The following is a description of a gene set: species: Homo sapiens Human Gene Set: GOBP_REGULATION_OF_DEVELOPMENTAL_GROWTH Any process that modulates the frequency, rate or extent of developmental growth., and this is the list of marker genes: FOXS1, RAB21, EDN1, FOXP1 (NCBI Gene Id 87246), KCNK2, RUNX1, ITSN2, GHRH, TP73, RTN4R, PPIB, YY1, NACA, CDKL3, SYT17, ARX, GATA6, STK3, AKT1, SMAD7, CDK1, GDI1 (NCBI Gene Id 2664), ADRB3, ATG16L1, TTL, MIR548C, GPAM, TBX2 (NCBI Gene Id 6909), MKKS, MIR200B, BCL2, NIPBL, EZR, SYT2, CLASP2, ZMPSTE24, GPAT4, SHTN1, SLIT1, NRCAM, APP, YAP1, FTO, TRPC5, ADCY10, COLQ, GPR21, SEMA7A, MIR19A, MIR1-1, PLAC8 (placenta associated 8), PLAA, HMGA2, CXCL12, SLC6A4 (solute carrier family 6 member 4), SERP1, GHRHR, RIMS1, NKX2-5, FN1, CTTN, STC2, CGA, VEGFA, PARP2 (poly(ADP-ribose) polymerase 2), SEMA3G, CREB1, NPY1R, LATS2, SOCS2, CDKN1B, RTN4, GHR, PIK3CA, ADRB2, ADNP, RNF6, EPPK1, SEMA3A, MAPK11, STK4, AFG3L2, FGF20, TBX5, PAFAH1B1, RIMS2, DCC, ADRB1, FOXC1, WNT5A, JARID2, IGF1, GHRL (ghrelin and obestatin prepropeptide), MFSD2A (MFSD2 lysolipid transporter A, lysophospholipid), NOG, MAP2, TGFBR1, SOX15, PLXNA4, GH1, SIX4, LGMN, MIR204, WWC2, POU3F2, RAG2 (NCBI Gene Id 5897), CACNA2D2, PTPRS, MIR17HG, CACNG7, ULK2, SPAAR, ISLR2, ZFPM2, ANAPC2, SEMA3F, ABL1, LIMK1, AR, NRG1, FXN, SGPL1, FGFR3, GLI1, CPNE5, HDAC3, MYOD1, SEMA6C, MIR509-1, DIO3, GDF15, FGFR2, LIN7A, DIP2B, BMP10, SIN3A, SIX1, CPNE6, AGR2, ACTN3, DRAXIN, MT3, SPART, CRABP2, DRD2, NEDD4L, AKAP6, PPARA, NGF, DNM2, HOPX, PEX5, SPP1, NOTCH1, ARHGAP4, SEMA6D, MIR590, KIAA0319, MAPT, RGS4, SLC6A3, PLXNA3, COL14A1, LATS1, BARHL2, RUFY3, RNF157, WWC3 (NCBI Gene Id 55841), DLL1, MIR208A, UNC13A, MUSK, MEF2C, CTDP1, WNT3, INSR, SEMA4D, SYT4, FOSL2, TRIM46, MIR873, IFRD1, CAV3, MIR199A1, APOE, CAPN3, MEGF8, MIR29B1, LPAR3, FGF13, STAT5A (signal transducer and activator of transcription 5A), NTN1, MIR19B1, BASP1, G6PD, ULK1, MIR222, RBPJ, GJD4, MSTN, RYK, MAG, EPHA7, TGFBR3, TNR, ZP3, HSF1, SMO, OLFM1, FGF8, TNFRSF12A, SOD1, HDAC6, LIN7C, HTRA2 (NCBI Gene Id 27429), PLS1, BMPR2, SYT3, MYOZ1, EFNA5, SAV1, RBP4, PTCH1, ACACB, CDKN1A, CDKL5, RGS2 (regulator of G protein signaling 2), DUSP6 (NCBI Gene Id 1848), ATRN, VGLL4, PPARD, NPPC, WNT2, LIN7B (NCBI Gene Id 64130), BDNF, LEP, CPNE9, MYCBP2, IL7, MAPK14 (NCBI Gene Id 1432), RND2, GOLGA4, NTRK3, RGMA, POU4F2, OSTN, GAMT, ERBB4, AGRN, GRN, STAT3, DSCAM, PIM1, TOMM70, PAK1, SEMA4F, ZFYVE27, MTM1, IGF2, HEY2 (hes related family bHLH transcription factor with YRPW motif 2), NRP1 (NCBI Gene Id 8829), GDF5, RAI1, GHSR, SLC23A2, BBS4, FOXC2, BCL2L11, MAP3K13, NKX6-1, GNAS, IST1, CFL1, VIL1, DUSP10, RASAL1, PTEN, GSK3A, SMURF1, TWF2, PI16, WWC1, MIR25, TLL2, SPTBN4, PROX1, MYH6, HNF1B, MIR199B, L1CAM, WT1, CSF1, TRPV2, SASH3, PLCB1, CDH4, CHD7, HLX, CDK5, SPAG9 (sperm associated antigen 9), GSK3B (NCBI Gene Id 2932), FGF9, FGF2, MACF1, YBX3, SUV39H1, BBS2, STAT5B, CDH1, SEMA5A, PUM2, SYT1, DISC1, PDZD11, FSTL4, P2RX5, WNT3A, PRLH, FLVCR1, SYT14P1, CCNB1, TBX20, MAEL, MAP1B, MBD5, MUL1, BCL11A, FGFR1, ATP8A2, PRKN, SRF, BMPR1A